Given this list of marker genes TMEM185B, SPP1, IFIT3, IFI44, LY6E, PDGFRL, GBP1, SP140, SP100, FFAR2, TNFAIP6, ZNF107, SOCS1, OLIG2, UPB1, MTF1, TAP1, IFIH1, STAT2, DRAM1, DYNLT1, TRAF1, MOB3B, TRIM21, IL6, TNFAIP8, GADD45B, ADAR, APOL1, OAS3, NBN, DUSP5, MT1HL1, IL12RB2, EIF2AK2, TRIM25, CMC2, RSAD2, N4BP1, IL17A, SAMD9, HLA-E, HERC5, LTA, LAP3, ISG20, TRIM38, IL2RA, USP18, OAS1, XAF1, AK4, SLAMF7, IRF9, ZCCHC2, CD164, BST2, CHMP5, SOWAHC, TRAFD1, AIM2, MT2A, TMEM140, MX2, YEATS2, APOL2, PSMB9, IFITM3, CFLAR, CACNA1A, TRANK1, TOR1B, CYP2J2, LAG3, TRAF3IP2 (NCBI Gene Id 25997), UBE2S (NCBI Gene Id 27338), ANKFY1, IFI16, SOBP, AIDA, INHBA, TRIM14, ATF3, BATF, IL3RA, SOCS3, SP110, SEMA3C, ISG15, SBNO2, KCNA3, PML, RTP4, LILRP2, TRIM26, TNF, HBEGF, RABGGTA, IFI35, NDUFV2, AGRN, IFIT2 (NCBI Gene Id 8375), KCNK15-AS1, PLSCR1, CALM1, PRDX4 (NCBI Gene Id 82852), CH25H, PARP11, SRC, ARID5B, RIPK2, LAMP3, TP53BP2, LNPEP, SLC30A3, NMI, CMTR1 (cap methyltransferase 1), BCL6, PHF11, DHX58, PARP12, NAPA, IL15RA, SHFL, CD47, RAPGEF2, IFI44L, PSMB8, DDX60, SMCHD1, CYRIA (NCBI Gene Id 81553), CCL4, MT1F, MRPL17, IL19, TNFSF10, IFIT5, TRIM5, ZBP1, CCNA1, MT1G, HLX, HERC6, CCN3, RIGI, TANK, ETS2 (NCBI Gene Id 2114), SPATS2L, IRF1, IFITM1, ADTRP, IFI6, TLR3, APOL6, C1GALT1, GTPBP2, TDRD7, CNP, FMR1, IRS1, RBCK1, DNAAF1, RASGRP3, LGALS3BP, MT1X, IFIT1, KCNJ2, STAT1, UBE2L6, LPIN2, CES1, STAP1, SLC2A6, OASL, HRH1, TREX1, TMEM255A (NCBI Gene Id 55026), BMAL2, CHST12, PSMA4, BCL2L14, IKZF3, IL1RN, FANCA, ENPP2, TMEM62, DNAJA1, BARD1, MT1H, TRIM22, CASP4, IRF7, MX1, SCARF1, OAS2, LYRM1, CASP5 (NCBI Gene Id 838), CD38, MT1E, TAP2, here is a description of the gene set: studied in species Homo sapiens from publication Querec TD, Akondy RS, Lee EK, Cao W, Nakaya HI, Teuwen D, Pirani A, Gernert K, Deng J, Marzolf B, Kennedy K, Wu H, Bennouna S, Oluoch H, Miller J, Vencio RZ, Mulligan M, Aderem A, Ahmed R, Pulendran B (PMID 19029902) Genes down-regulated in comparison of unstimulated peripheral blood mononuclear cells (PBMC) versus PBMC stimulated with YF17D vaccine. The immune responses generated by YF-17D by profiling genes in PBMCs from 2 donors cultured with YF-17D vaccine were accessed after 3 and 12 hours. Human Gene Set: GSE13484_UNSTIM_VS_YF17D_VACCINE_STIM_PBMC_DN